Given this list of marker genes Drd4, Tescl, Tesc, Chp1, Plcb1, here is a description of the gene set: Any process that activates or increases the activity of a sodium:hydrogen antiporter, which catalyzes the reaction: Na+(out) + H+(in) = Na+(in) + H+(out). studied in species Mus musculus Mouse Gene Set: GOBP_POSITIVE_REGULATION_OF_SODIUM_PROTON_ANTIPORTER_ACTIVITY